The following is a description of a gene set: species: Mus musculus from publication Yevshin I, Sharipov R, Kolmykov S, Kondrakhin Y, Kolpakov F (PMID 30445619) Mouse Gene Set: ZFP296_TARGET_GENES, and this is the list of marker genes: Eif1a, Dnajc17, Ly6g6c, Adap1, Cpsf4l, Mrpl44, Gm23143, Gm8357, Hspe1, Eddm13, Zfp568, Sfxn5, 4933427D14Rik, Ackr4, Tacc3, Rnf216, Snora7a (small nucleolar RNA, H/ACA box 7A), Snrpd1, 4930432B10Rik, Lamtor2, Mir6236, Plpp1, Slmap, Ubl7, Oplah, Rif1, Polg, Dnase1l1, Azin2, Epc2, Myo10, Mir25, Mars2 (NCBI Gene Id 212679), Prdm2, Apobec3, Gm30238, Chaf1b, Med1, Tor1aip1, Gm22965, Srrm4os, Rmrp, Plin2, Gm12974, Gm53, Bag2 (BCL2-associated athanogene 2), Wdr81, Rpl32, Mcm7, Ubqln4, Lasp1, Inf2, Gemin7, Zfp687, Tmed7, Rdm1, Taco1, Gm10535, Pcca, Nav2, Ddx18, Tmem39a, Commd9, Armc9, Gns, Ppp3ca, Triap1, Slc25a39, Clcnka, Ptpn23, Calcoco1, Gm19705 (NCBI Gene Id 100503460), Gm14204, Nek4, Anxa11, Zfp738, Comtd1, 4930481B07Rik, Thap4, Slc25a33, Man2c1, Adm2, Cdc40, Gulp1, Pimreg, Tbx3, Tmc6, Esp38, Fbxo30, Phf12, Slc30a1, Dnah14, Cpt2, Rcbtb1, Ccdc146, Homez, Man2c1os, 5330429C05Rik, Cdyl, Erf, Mdm2, Ctbp2, Rplp0 (NCBI Gene Id 64336), 4930524O07Rik (RIKEN cDNA 4930524O07 gene), Cisd1, Rbm25, Setd4, Rcan1, Mitd1, Gm16510, Alox12, Nudt13, Gm10222, Ndc1, Gabarap, Prss48, Trmt44, P2ry2, Itga6, Gm11528, Pcdhga1, Grn, A830008E24Rik, Uqcc4, Klhdc4, Pou5f1, Plekha4, Ttc39b, Rgma, Zfp235, Zfyve19, Tmem62, Tafazzin, Ephb4, Fbxo27, Pctp, Zfp319, Fam133b, Trim71, Ppp1r9a, Trpc4ap, Tmem181b-ps, Abhd6, Fblim1, Tmem128, Ddx46, Fbxw8, Ston1, Mir93, Mfsd5, Zfp146, Marchf8, Snhg17, Lhfpl7, Cyp39a1, Plekhd1os, Rnu7, A430057M04Rik, Gm12100, Fam185a, Zfp532, Dgke (NCBI Gene Id 97759), Mymx, Xbp1, Mmp14, Ccnc, Gm15401, Clk1, Tagln3, Schip1, Cenatac, Gls, Tirap, Tefm, Dnase2a, Gm11292, Hspd1, Zbtb7b, Celrr, Msln, Prpf18, Rin1, Nceh1, Cnpy4, Rnf182, Taf6, A930012L18Rik, Myh10, Peds1, Tmbim4, Plekhf1, Sox7, Gm5113, Cpeb2, Manf, Cenpj, Rab29, Foxp4 (forkhead box P4), Xaf1, Fam227a, Rpl30-ps6, Gm16794, Cd37, Nsmaf, Tnrc18, Asns, Gm15564, Timm13, Def8, Nfkbiz, Ly6e, Sun1, Calm3, Prim2, Hat1, Ptov1, Sgo2a, Trim7 (NCBI Gene Id 94089), Top2b, Gm2093, 4921531C22Rik, Sumf1, Mir3063, Fbln7, Stx16, Zfp563, Mtmr2, Rimbp2, Mir106b, Prdm14, Septin1, Nudt9, Brwd1, Tle6, Pgk1, 2410021H03Rik, Tex14, Rpl7, Rnf6 (NCBI Gene Id 74132), Hexb, F11r, Rgs7, Kdm2b, Sema3b, Xrn1, Thbs3, Dohh, Rab11a, Txndc17, Cbr3, Max, Cby1, Dhrs13, Pxdn (NCBI Gene Id 97824), 2610005L07Rik, Rps29, Wfikkn1, Wee1, Slc29a3, Ctdsp1, Glis2, Wdfy1, Riok3, Stmn1, Cryba4, Usf2, Cdc34, Suclg1, Pde11a, Grcc10, Usp8, Vps26c, Gtf3c6, Rbm47, Pipox, Eny2, Rnf220, Platr22, Uba2, Pld2, Cd55, F2rl1, Gm13816, Ccdc63, Cfap418, Gm14320, E130311K13Rik, Ccdc107, Wasf1, Slc25a27, 1700064H15Rik, Arhgap9, Zscan22, 6820431F20Rik, Coa3, A530072M11Rik, Bmpr2, Rarg, Zfta, Igf2, Usb1, Rps3a1, Atp6v1e1, Tmem129, Mrpl30, Clcn7, Hmces, Rpl7l1, Pcolce, Paxbp1, Upp1, Lmo2, Srpra, Zfp184, Tspan15, Knl1, Zfp788, Ptbp3, Calu, Gys1, Med4, Ddx3x, Arhgef39, Amotl2, Cntd1, Gjc1, Prcc, Alyref2, Slco5a1, Insig1, Nt5dc3, Cbx7, Rwdd1, Telo2